The following is a description of a gene set: Neighborhood of PRKDC Human Gene Set: MORF_PRKDC Neighborhood of PRKDC protein kinase, DNA-activated, catalytic polypeptide in the MORF expression compendium studied in species Homo sapiens, and this is the list of marker genes: BUB3, RAD54L, RPN1, EI24, BUB1B, DNAJC8, CNOT1, MCM5, MCFD2, SNRPA, YWHAQ (tyrosine 3-monooxygenase/tryptophan 5-monooxygenase activation protein theta), SEPTIN7, DCTD, TFAP4, RPA2, GNL2, USP14, PRPF8, DNMT1, PDHB, IDH3A, BAZ1B, PGM1, LANCL1, ANKRD17, PLPBP, GOT2, SSB, GNG5, CAPZA1, ATP5MC3, PDXDC2P-NPIPB14P, ILF2, GPN1, ATP5PO, TCEA1 (NCBI Gene Id 7865), RPIA, XPO7, AATF, DFFA, RRM1, VDAC3, CDK11A, STARD7, HNRNPR, NSUN5P2, SLBP, MRPS18B, YARS1, RUVBL1, LBR, DDX19B, AKR7A2, CS, BMI1, MZF1, DDX46, HNRNPU, TYMS, SRRM1, HADH (NCBI Gene Id 3033), DKC1, DEAF1, MTREX, EIF1AX, CDC16 (NCBI Gene Id 8881), KXD1, NUDC, ABCF1, TXNL4A, TFDP1, IFRD2, HNRNPL, CDK2, TCOF1, XRCC5, PKMYT1, PPIE, MMS19, CCT5, EIF2S2, PIN1, TM9SF2, SNRNP200, ESD, SCARB1, NSD2, SSRP1, NUP62, CHAF1A, DUT, RNPEP, KHDRBS1, NONO, PTDSS1, HNRNPD, PSMD3, POM121, IARS1, TUBA3C, PPP1CC (protein phosphatase 1 catalytic subunit gamma), LRPPRC, SRPK1, MCM2, GARS1, USP1, EIF3I, AK2, AFG3L2, MTCP1 (NCBI Gene Id 4515), MCM6, DIAPH1, ALG3, NUDT1, CDKN2C, PRPF31, BMS1, RFC4, PWP2, ANP32A, SAFB, HCFC1, WDR18, MLEC (malectin), NAGA, ACTL6A, GPAA1 (NCBI Gene Id 8733), SHMT2, TNPO3, PABPC4, VDAC2, ATXN10, CEBPZ, SEC63, PABPN1, DDX39A, CCT4, CTDNEP1, ARIH2, XPO6, UPF3A, TRRAP, IMMT, TARS1 (NCBI Gene Id 94887), POLR2A, COQ9, FH, CDC7, THOP1, DDX18, SMARCC1, ZPR1, SSBP1, MARS1, PSMA1, PRPS2, GNB1, HMGN4, XPO1, TXLNA, DDB1, RUVBL2, RAD23A, BRD8, VARS1, CAMKK2, LSM2, PRKDC, TREX2, PDIA3, ZWINT, KHSRP (NCBI Gene Id 8570), CAD, NAE1, NPM3, HDAC2, HNRNPA2B1, MRPS27, MCM3, DNAJC11, NUP188, TIMM17A, ARID3A, GTF2A2 (general transcription factor IIA subunit 2), EPRS1, ZNF131, PSMD2, TRIP13, SREBF2, ANAPC5, TCP1